Given this list of marker genes PLA2G4A, PLA2G4C, GPCPD1, PLBD1, PLA2G15, PLA2G4B, PLA2G4F, PLA2G4E, PLA2G4D, here is a description of the gene set: studied in species Homo sapiens Hydrolysis of LPC Human Gene Set: REACTOME_HYDROLYSIS_OF_LPC